The following is a description of a gene set: Human Gene Set: GOCC_FILOPODIUM Thin, stiff, actin-based protrusion extended by the leading edge of a motile cell such as a crawling fibroblast or amoeba, or an axonal or dendritic growth cone, or a dendritic shaft. species: Homo sapiens, and this is the list of marker genes: EPHB1, UTRN, MTM1, CDK5, RAPH1, TENM2, RDX, ITGAV, ERMN, MYO3A, ABI1, MYO1B, ACTC1, PPP1R9B, NLGN1, TWF1, KITLG, DMD (dystrophin), MORN4, WASH3P, MYO1G, CIB1, SCIMP, IGF2BP1, ACP3, RIPOR2, LY6G6D, SPATA13, FARP1, GPM6A, SHTN1, ACTA2, CXADR, FGD4, MYO3B, BAIAP2, MAP2, CFL1, UBE2Q1, ACTA1, FZD9, PODXL, MYO6, EZR, FSCN1, DEF6, DYNC1H1, FMR1, ITGB1, ABI2, PPP1R9A (NCBI Gene Id 55607), ITGA3, NOS1AP, DAG1, SYNE2, MSN, ADGRA2, CDC42, EPHA4, AP2A1, INPPL1, TRPV4, NGDN, TTYH1, APP, FGF13, HLA-G, VCAM1, LCP1, B4GALT1, TBC1D10C (NCBI Gene Id 374403), ARF6, MYO5A, TM4SF19, FZD3, VASP, TUBB3, ANTXR1, GAP43, TWF2 (twinfilin actin binding protein 2), OSBPL3, RAPGEF3, CD302, FAT1, UNC5C, ITGB3, PDPN (podoplanin), ABITRAM, VIL1, NF2, IQGAP2, FSCN3, DNALI1, ARL4C, ACTG2 (actin gamma 2, smooth muscle), ENAH, SPEF1, PALM (NCBI Gene Id 5064), NHERF1, UBE2K, RUFY3, MYO10, DYNC2I2, TIAM2, ACTN2